The following is a description of a gene set: species: Mus musculus Chylomicron assembly Mouse Gene Set: REACTOME_CHYLOMICRON_ASSEMBLY, and this is the list of marker genes: Apoa2, Apoa1, Apoc2l, Apoa4, P4hb, Mttp, Apoe, Apoc2, Apob, Sar1b